Given this list of marker genes Baiap2l2, Marcks, Aif1, Tnnt2, Gas2l1, Cobl, Eps8, Baiap2l1, Dpysl3, Flna, Diaph3, Gas2l3, Gas2l2, Gas2, Baiap2, here is a description of the gene set: species: Mus musculus Mouse Gene Set: GOBP_ACTIN_CROSSLINK_FORMATION The process in which two or more actin filaments are connected together by proteins that act as crosslinks between the filaments. The crosslinked filaments may be on the same or differing axes.